The following is a description of a gene set: A process in which a host organism modulates the frequency, rate or extent of viral RNA genome replication. species: Mus musculus Mouse Gene Set: GOBP_MODULATION_BY_HOST_OF_VIRAL_RNA_GENOME_REPLICATION, and this is the list of marker genes: Vapb, Fbxl2, Phb1, Tmem41b, Fmr1, Ddx56